The following is a description of a gene set: Regulation of retinoblastoma protein from publication Schaefer CF, Anthony K, Krupa S, Buchoff J, Day M, Hannay T, Buetow KH (PMID 18832364) Human Gene Set: PID_RB_1PATHWAY studied in species Homo sapiens, and this is the list of marker genes: CCND2 (NCBI Gene Id 894), DNMT1, CCNE1, MAPK11, TGFB2, SPI1, SFTPD, ELF1, MAPK14, SKP2, CBX4, PPARG, E2F1, HDAC3, JUN, SIRT1, CCND1 (NCBI Gene Id 893), PAX3, CCND3, CCNA2, E2F3, PPP2R3B (NCBI Gene Id 28227), CEBPD, BGLAP, CEBPA, SMARCB1, MET, TFDP1, TBP, CDK6, MEF2C, RUNX2, ATF7, SUV39H1, CDKN1A, EP300, MDM2, MAPK9, CKM, RB1, E2F4, TAF1, E2F2, CREBBP, AATF, CEBPB, PPP2CA, CTBP1, RBP2, BRD2, GSC, CDKN2A, HDAC1, CDK4, CDK2, SMARCA4, CSF2, RBBP4, ABL1, UBTF, MYOD1, MITF, RAF1, ATF2, CDKN1B